The following is a description of a gene set: Genes down-regulated in T reg: wildtype versus ADORA2A. species: Homo sapiens from publication Kinsey GR, Huang L, Jaworska K, Khutsishvili K, Becker DA, Ye H, Lobo PI, Okusa MD (PMID 22835488) Human Gene Set: GSE34006_WT_VS_A2AR_KO_TREG_DN The adenosine 2A receptor (A2AR) is expressed on regulatory T cells (Tregs), but the functional significance is currently unknown. We compared the gene expression between wild-type (WT) and A2AR knockout (KO) Tregs and between WT Tregs treated with vehicle or a selective A2AR agonist., and this is the list of marker genes: ZFYVE26, PMEPA1, SLC25A22, TRAFD1, APOBEC3B, GPR65, KCNC4, IRF7, PWP2, PARP9, ILRUN, DHX58, ASB5 (NCBI Gene Id 140458, ankyrin repeat and SOCS box containing 5), FAM111A, IP6K1, DDX24, IFIT3, UTS2R, ZNFX1, DBN1, TFAM, LGALS9B, ZFP90, ZMYND11, AIDA, PEX26, RNF19B, USP18, JCHAIN (joining chain of multimeric IgA and IgM), PSME2, STAT1, USP38, C19orf12, PPP1R10, FEZ1, GRINA, CD274, ETNK1, C1orf159, VPS50, TOR1AIP2 (torsin 1A interacting protein 2), IFIT1B, OGFR (opioid growth factor receptor), SYNE2, MAK, LPAR4, GPR155, MTAP, ANKFY1, MX2, SHFL, PNPT1, KEAP1, TRIM34, CFHR1, FIGN, RBM43, TAPBPL, PHF3, TAPBP, INSL6, MOV10, ERG28 (ergosterol biosynthesis 28 homolog), IGKC, SMAD1, IDNK, B2M, DAXX, MX1, HELZ2, MMP1, PIGA, CASP7, NRG4, IRF1, SLC7A1, IFIT2, USP36, DEFB4A, DIP2B, KCNQ1, PRKCG, CYP1B1, TOR1AIP1, TMEM140, CDH23 (NCBI Gene Id 7395), GBP7, PSMB10, ATRN, EIF4E3, MTARC2 (mitochondrial amidoxime reducing component 2), LMO4, TAP1 (NCBI Gene Id 92050), CXCL10, GBP2, IFI27L2, GBP6, TDRP, IFIH1, FZD7, TSPAN1, NAA20, RSAD2, PPA1 (inorganic pyrophosphatase 1), PARP14, GCH1, FAP, SOCS1, MGAT1, TRAF4, CCRL2, ACADL, PNPLA2, FNBP4, IGHMBP2, TRIM21, OASL, OAS2, RNF114, DNAJC13, CHIC1, RFC3, ATP1B2, PSME1, TLR7, TSTD1, LAPTM4A, ISG15, TNFSF10, NNT, IFI35, PLAAT1, TMEM184B, PDXDC1, GBP4, SSBP2, PLS1, TNIP2, CCND2, NMI, CMPK2, CASP8, HLA-E, VCAN, CUEDC1, TEAD4, PML (PML nuclear body scaffold), MAP7, RIPK1, ULK2, PSMB8, LANCL1, SAMHD1, PARP12, GEMIN6, TOR3A, ADAR, PSMB9, IRGM, CD151, STAT2, ASB13, BST2, ATP11B, NOC4L, CFAP418 (cilia and flagella associated protein 418), PDK1, OAS3, SLC25A28, TMBIM6, TRIM26, PKIA, TRIM25, RTP4, DDX60, MITD1, ARID5A, ATXN1, DCAF11, AQP1, ZUP1, HLA-C, CMTR1, OAS1 (NCBI Gene Id 4938), PLSCR3, XPNPEP2, SLFN12L, IRF9, SLC2A4, SLFN13, HLA-B, ISG20, SLAIN1, ZBP1, TDRD7, SLC5A1, DOLPP1, MORC3, PCCA, GMPPB